Given this list of marker genes GAS2L1, DAPP1, PDE3A, FAM81B, MAP3K7CL, VCL, ANKDD1B, VIL1, MYEOV, PRKCA-AS1, CENPT, CAPN1-AS1, C2orf88, DEFB108B, SPDYC, RNF11, VIM-AS1, LINC01750, PIP4P2, SLC18A2-AS1, H3C10, STON2, PPBP, GP6, AQP10, CLEC2L, SCGB1C2, MYLK, NEXN-AS1, NT5C3A, UBL4A, BAMBI, H2AC8, TMBIM1, EHD3, TSPAN18, PDLIM7, RSPH9, UBAC2, WDR11-DT, PDGFA-DT, LEFTY1, TSPAN9, PNMA1, SLC18A3, TAGLN2, DNAAF3, RGS10, AVPR1A, MOB3C, H2BC11, RGS18, CHST8, TMEM140, TDRP, BEX3, LURAP1L, GSTO1, MAOB, MMD, BCL2L1, CHRNA2, ELOVL7, RGS6, H4C14, TSC22D1, F13A1, SLC24A3, SLC6A4, PEAR1, OXTR, AFAP1, PROS1 (NCBI Gene Id 5627), WBP2, CNST, LAMTOR1, SH3BGRL2, PTPRN, SCGB1C1, TPTEP1, PDE11A-AS1, ENSG00000250348, PDZK1IP1, ESAM, ABLIM3, CNN1, ENSG00000266401, SPNS1, SWI5, ENDOD1, LGALS12, CXCL5 (NCBI Gene Id 6374), PCYT1B, F2RL3, SRC, MARCHF2, SPARC, MINDY1, SCN1B, H2BC21, UPK1A-AS1, VEPH1, ICAM2, RAP1B, KIF2A, FAXDC2, MEPCE (methylphosphate capping enzyme), NCOA4, PDGFA, PGRMC1, DNM3, LGALSL, PARD3, ACRBP (NCBI Gene Id 84519), LY6G6F, GNAZ, TLN1, NFE2, ADGRG7, LCN2, NEXN, CABP5, ARHGAP18, MEIS1, MTURN, CALHM5, BMP6, ABCC3, LINC00635, PTPN18 (NCBI Gene Id 26469), SLFN14, GP9, CMTM5, GCKR, DCLRE1A, C19orf33, PVALB, TBXA2R, ODC1, RUFY1, FRMD3, CLEC1B (NCBI Gene Id 51266), SMIM5, ALOX12, GNG11, BPIFB3, TREML1, TRIM40, SMOX, CYB5R1, BDNF, GP1BA, LYPLAL1, WDR1, CD151, TUBA8, LINC02704, SEPTIN5, ARMC3, ENSG00000240497, PTGS1 (prostaglandin-endoperoxide synthase 1), CD226, BEND2, RAB6B, SENCR, KIFC3 (kinesin family member C3), LYL1, MPIG6B, LANCL3, WFDC10B, RHOBTB1, MISP3, FAM187B, TMEM91, LINC00989, TNFSF4 (TNF superfamily member 4), MYL9, AFAP1L2, RD3L, HSD17B3 (NCBI Gene Id 3293), FSTL4, TRIM58, IGF2BP3, DENND2C, ARHGAP6, CLU, AFAP1-AS1, MORC1, LY6G6F-LY6G6D, ATP9A, RAB27B, TNNC2, FRMD4B, ENSG00000245008, LIPH, GET1, CTDSPL, LINC00853, OST4, GRAP2, GRHL1 (grainyhead like transcription factor 1), TUBA4A, CAPN1, TMEM40, TUBB1, ZCCHC17, CTTN (NCBI Gene Id 2017), ZNF438, PF4, DAB2, AHCTF1, PF4V1, LINC01088, LINC01151, EMC3 (ER membrane protein complex subunit 3), CDKN2D, LIMS1, ILK, FERMT3, PTCRA (pre T cell antigen receptor alpha), SAMD14, TNNI3, SNAP23, PDE5A, NRGN, INKA2, CERS2, RASGRP2, MYZAP, C1orf116, SYTL4 (synaptotagmin like 4), ITGB3, CAVIN2, LINC02319, TRAPPC3L, H2AC6, SLC35D3, C1orf87, RTN2, ASAP2, SPOCD1, MLH3, PTGIR, RAB11A, REEP1, GMPR, CTSA, PLEKHO1 (NCBI Gene Id 51177), R3HDM4, THEM5, RSU1, HEXIM2, SEC14L5, SELP, LINC02915, INKA1, XPNPEP1, MFAP3L, INKA2-AS1, PDCD10, CFAP161, EGF, PSTPIP2, MAX, PCP2, LINC00642, HGD, TPM4 (NCBI Gene Id 7171), AP1M2, ENKUR, CLDN5, TMCC2, PLAAT1, COL25A1, here is a description of the gene set: Human Gene Set: HAY_BONE_MARROW_PLATELET from publication Hay SB, Ferchen K, Chetal K, Grimes HL, Salomonis N (PMID 30243574) studied in species Homo sapiens